The following is a description of a gene set: The series of molecular signals initiated by the binding of the Fc portion of immunoglobulin G (IgG) to an Fc-gamma receptor on the surface of a target cell, and ending with the regulation of a downstream cellular process, e.g. transcription. The Fc portion of an immunoglobulin is its C-terminal constant region. species: Homo sapiens Human Gene Set: GOBP_FC_GAMMA_RECEPTOR_SIGNALING_PATHWAY, and this is the list of marker genes: APPL2, FCGR3A, YES1, FCGR1BP, APPL1, PAK1 (p21 (RAC1) activated kinase 1), PLA2G6, CLEC4E (NCBI Gene Id 26253), IFNG, FCGR2C, SRC, FCER1G, CLEC4D, PRKCE, FCGR2B, SYK, CD247, FCGR2A, FCGR1A, PRKCD, VAV2, FGR, HCK, FYN, LYN, PLD2, ABL1, LIMK1, CD33, PTK2, LCK, VAV1, MYO1G, NOS2, FCER2, FCGR3B, PLPP4, VAV3